Given this list of marker genes Card9, Ripk2, Nfkbia, Trim41, Jag1, Nlrp1a, Rela, Chmp5, Nod1, Nagk, Tnfaip3, Erbin, Mapk14, Ldoc1, Inava, Irf5, Vim, Nod2, Notch1, Ptpn22, Arhgef2, here is a description of the gene set: Any process that results in a change in state or activity of an organism (in terms of movement, secretion, enzyme production, gene expression, etc.) as a result of a muramyl dipeptide stimulus. Muramyl dipeptide is derived from peptidoglycan. Mouse Gene Set: GOBP_RESPONSE_TO_MURAMYL_DIPEPTIDE species: Mus musculus